Given this list of marker genes Gm12327, Txndc17, Or3a10, Rabep1, Or1e19, Mis12, Or1e31, Gm22927, P2rx1, Gm19967, Ctns, 4933427D14Rik, Gm23226, Or1e29, Shpk, Ncbp3, 6330403K07Rik, Itgae, Gm12322, Zfp616, Gm16021, Trpv1, C1qbp, Emc6, Or1e28-ps1, Gm12712, Gm24143, Aipl1, 1700051A21Rik, P2rx5, Or1e25, Rpain (RPA interacting protein), Atp2a3, Zzef1 (zinc finger, ZZ-type with EF hand domain 1), Gm22381, Or1e23, Gm12331, 9230020A06Rik, Camkk1, Rpl23a-ps2, Nlrp1a, Gm22297, Tekt1, Or3a4, Or1e1b-ps1, Or1e30, Or1e1, Cyb5d2, Gm33351, Gm6733, Spns2, Haspin, Spns3, Or1e22, Zfp735, Med31, Or1e32, Spata22, Ube2g1, 4930563E22Rik, Or1e33, Tax1bp3 (NCBI Gene Id 76281), Or1e34, Or1e1c, Or1e18-ps1, Mybbp1a, Wscd1, Gm15377, Smtnl2, Or1e1d-ps1, Xaf1, Or1r1, Or1e35, Fbxo39, Gm12326 (predicted gene 12326), Nlrp1c-ps, Nup88, Or1e20-ps1, Gm26121, Slc13a5, Derl2, Or1e17, Or1e36-ps1, Dhx33, Or1e16, Or1e24-ps1, Trpv3, Ggt6, Or1e1f, Nlrp1b, Or1e21, 4732414G09Rik, Gm17811, Aspa, Pimreg, Gm16013, Gm12321, 4930401O10Rik, Mir6338, Or1e26, Ankfy1, Pitpnm3, Or1e27-ps1, here is a description of the gene set: studied in species Mus musculus Mouse Gene Set: chr11B4